The following is a description of a gene set: studied in species Homo sapiens Neighborhood of TERF2IP telomeric repeat binding factor 2, interacting protein in the MORF expression compendium Human Gene Set: MORF_TERF2IP Neighborhood of TERF2IP, and this is the list of marker genes: POLR2A, DENND4A, CPSF4, B4GALT3, RABAC1, TFAP4, DNAJC8, CAPZB, HNRNPH2, SLC9A1, CNBP, GNB5, BRD3, BRD8, IK, COPS6, ZFTRAF1, CNOT4, SEPTIN7, NFATC2IP (NCBI Gene Id 84901), RAF1, TAF9, SDR39U1, CNOT1, RAB11A, KHDRBS1, UBE2D3, HNRNPH3, HNRNPK, PARN, RTCB, RPS27A, SMNDC1, PRKCSH, MORC3, CHD8, YWHAQ, CNOT2, WWOX, DRG1, NFYB, SRRT, PLIN3, DNPEP, SNRNP200, TP53BP1, DRG2, NACA, SMARCC2, IST1, SMC5, DYRK2, CALM2, PWP1, SEC61B, BECN1, TERF2IP, KDM3B, NUDT3, MKRN1, ILF2, NUBP1, EIF4H, SMAD2, MARCHF7, COX7A2L, ALDH4A1, STK38, UBN1, CANX, TIAL1, ARFGAP2, OTUB1, RPRD2, PPP2CA, AATF, CUX1, XPO6, PRKAG1, CSNK1D, NELFB, PHB1, SUMO2, ZNHIT3 (zinc finger HIT-type containing 3), MFN2, CLSTN1, FBXO7, GPAA1, EAPP, ROCK1, DEK, ZC3H15, STK19, TOR1AIP1, SH2B1, CNPPD1, KBTBD2, AGPAT1, SFSWAP, FOXJ3, PRKRA, ATXN2L, CNP, OARD1 (O-acyl-ADP-ribose deacylase 1), TPR, KRAS, RAB1A, METAP1, EIF4A2, H3-3A, DDB1, NAP1L4, HTATSF1, TBCC, SLC25A36, DHX38